The following is a description of a gene set: Human Gene Set: MIR3194_3P Genes predicted to be targets of miRBase v22 microRNA hsa-miR-3194-3p in miRDB v6.0 with MirTarget v4 prediction scores > 80 (high confidence targets). species: Homo sapiens from publication Chen Y, Wang X (PMID 31504780), and this is the list of marker genes: TMEM199, SMU1, TICAM2, GID4, FH, RAB43, PPP4R1, TRDN, MDM4, ZSWIM6, SAMD8, ZFYVE16, ATF3, RCC1, RAB30, LMNB1, SPRED1, SSH2, SMAD3, BTBD9 (BTB domain containing 9), C9orf163, KIAA0586, ZNF264, WASHC4, ZNF652, SPPL2C (NCBI Gene Id 162540), WWTR1, SMAD6, RPS6KB1, CD300E, TMED7-TICAM2, SMURF2, CDX1, CSPG5, PTPRR (NCBI Gene Id 5801), RIMS3, ASPN, RNF166, RPS6KA5, DENND1B, GPHN, SNN, CEMIP2, ARHGAP19, HMG20A, MMP16, MTMR7, SAMD12, SSBP2, NOL9, MARCHF2, HESX1, MAPRE1, ITSN1, MS4A4A, TRNT1, CSNK1A1, ABL1, ZNF547, NREP, MYO10, TMEM132B, NXPH1, PTPRF, CAPN7, FIBIN, DIRAS2, ADCY1, ARPIN, ZNF326, TFG, ROCK1, B4GALT4, MFN2, SYNJ1, XPO7, TMEM14A, SYT2, SCN8A, VSIG10, LANCL3, TANGO2, PRRG4, TMEM72, MECP2, PPM1F, EPHA10, CREBRF, SYT11, PAX5, KIAA1549, FAM117A, ARID3B, CTDP1, MFHAS1